The following is a description of a gene set: studied in species Homo sapiens Genes predicted to be targets of miRBase v22 microRNA hsa-miR-6805-5p in miRDB v6.0 with MirTarget v4 prediction scores > 80 (high confidence targets). from publication Chen Y, Wang X (PMID 31504780) Human Gene Set: MIR6805_5P, and this is the list of marker genes: NFE4, GANAB, ZNF687, BAZ2A, SOX12, GAD2, PPP1R16B, CHN1, TP53INP2, TSPAN1, TIMM10B, DMBX1, ASL, ESYT3, GREM2, MFSD9, BTN3A1, SHANK1, PRRC2A, CHD5, RHOC, NFATC1, NR1D1, PBX2, SCNN1A, ATP2B2, SRR, KCNB1, SYNGAP1, LRRC75A, SLC25A21, SMIM24, TBC1D13, BAIAP2L2, SSBP3, ERF, MEGF11, KMT2D, MXI1, RNF141